Given this list of marker genes SIX1, WNT3A, TFAP2C, MED1, NKD1, WNT11, VANGL2, SFRP1 (secreted frizzled related protein 1), HNF1B, AREG, SIX4, TNC, SFRP2, TGFB1, YAP1, TRIM28, MED12, SPRY1, FGFR2, BMP4, FGF1, FGF10, SHH, SPRY2, ESR1, WNT5A, PTK7, RDH10, SOX9, PPP2R3A, HOXD13, here is a description of the gene set: species: Homo sapiens Human Gene Set: GOBP_AXIS_ELONGATION The developmental growth that results in the elongation of a line that defines polarity or symmetry in an anatomical structure.